The following is a description of a gene set: Platelet-mediated interactions with vascular and circulating cells Human Gene Set: WP_PLATELETMEDIATED_INTERACTIONS_WITH_VASCULAR_AND_CIRCULATING_CELLS species: Homo sapiens, and this is the list of marker genes: CCL5, TGFB2, TLR2, SELPLG, ICAM1, IL1B, SELP, SELE, TGFB3, TLR4, TLR7, VCAM1, CD40LG, PF4, CCL2, CD40, TGFB1